Given this list of marker genes PLXNB1, CSNK1A1, GPR4, MCF2L, RAC1, TEK, ROBO1, LPAR2, ARHGEF3, F2R, PRAG1, GPR55, SYNPO2L, FXR1, F11R, ARHGEF10, ARRB1 (arrestin beta 1), APOA1 (NCBI Gene Id 335), F2RL1, LPAR1, COL3A1, NET1, SEMA4D, AKAP13, ABRA, RTN4R, ERBB2, ADGRG1, FERMT2, here is a description of the gene set: Any process that activates or increases the frequency, rate or extent of Rho protein signal transduction. Human Gene Set: GOBP_POSITIVE_REGULATION_OF_RHO_PROTEIN_SIGNAL_TRANSDUCTION studied in species Homo sapiens